The following is a description of a gene set: Genes in the cancer module 459. Human Gene Set: MODULE_459 species: Homo sapiens, and this is the list of marker genes: LEPROTL1, TMEM62, NOL7, CCAR2, FBXO11, MMP7, CDH5 (NCBI Gene Id 1003), RNF103, SENP1, PDCD6, BAIAP3, AMZ2, MPRIP, SLC11A2, TMED3, ACSM5, SCARA3, MAPK4, ZNF143, KATNAL1 (NCBI Gene Id 84056), KLHL41, EPHB6, RNASE6, TMEM144, CDK11A, SLC22A3, RPAP3, CD163, MST1R, INO80B, CD1A, PCGF1, NADSYN1, CORIN, RRAGD, TIMP4, SEMA4A, REV3L, SV2B, GEMIN7, TMEM161A, TMEM120A, CST1, GOLGA4, BTN2A1 (NCBI Gene Id 11120), COL6A3, HNRNPDL, BRAP, CHD1, SIAH1, EEF1D, SLC25A27, PARS2, CCNL1, PHAX, PLEKHM2, MMP9, PRPF39, KLHL4, SNRNP25, GRAPL-AS1, LRP3, PIP4K2C, LMTK3, NCF2, RNF220, ACVR1, PLGLB2, WRNIP1, LY9, STRN, CDH4, NECAP2, SUGP2, GPATCH3, ALKBH4 (alkB homolog 4, lysine demethylase), PHIP, SURF6, PAPOLA, EPB41L4B, ZMYM5, GEM, UGCG, GSN, GPR68, ATG16L1, OR2A1, MAGED4B, ACKR1, BEGAIN, TIMELESS, RBM7, AHNAK, NCOA7, NUP58, XPO4, FN1, ZGRF1, GJA1, ITGB5, CITED2 (NCBI Gene Id 154106), CAND1, EPHA7, TLN1, SPMAP2, ITM2C, PPP4R2, BCL2L14, CYP2A7, SLC19A1, OBSCN, ITGA4, CD8A, CHST9, NOP53, ELAC1, DDX60, CEP162, HMGN5, COCH, CYP1A1, MED12L, MRPL47, CXCL10, CCDC90B, MOB4, CTSZ, PAWR, ZBTB5, TMEM255A, NUP54, NACAD, ARHGAP20, ZNF117, IPCEF1, SLMAP, IL1RL1, MFSD1, SNX5, MAP2K6, CCDC81, KLHL36, MRPL27, WDR19, CELF2, ESPN, CXCL8, EIF2B4, TOR4A, DZIP3 (NCBI Gene Id 9666), MORC3, KATNIP, MREG, C1orf116, SFRP1, MICALL1 (MICAL like 1), SLC43A1 (NCBI Gene Id 8501), ACTR6, FMN1 (NCBI Gene Id 649014), POLDIP3, CACNA2D3, SMG7 (NCBI Gene Id 9887), MRPL36, BAG3, KAT2B, CCBE1, NELFB, HS1BP3, PCED1B, ZNF318, GJC2, DEXI, EYA3, OXGR1, TUBA4A, CCL2, TRIM48, FGFR1, TMCC2, FAIM, BCR, INIP, ART3 (NCBI Gene Id 419), APTX, NELFCD (NCBI Gene Id 51497), BFSP2-AS1, LARP1, ARG1, RPRM, WDR46, ILRUN, FGD6, TMEM47, MAL2, CSF2RB, RNF213, PDE4D, FBXW4, PAQR5, PIF1, DIO3, LYZ, PORCN, LANCL2, OTOR, PYGB, TNFRSF13C, DCTN3, PI4K2B, CEBPZ (CCAAT enhancer binding protein zeta), ARID5A, GPSM3, NME1, USP36, ZDHHC2, CDH22, PTGS2, LINC00160, IL1A, LACTB, LRRC14, ATG2A, FPR2, QSER1, CHD9, PLEKHG1, TFPI2, XRN2, ITK, ABI3, FUCA1, AASS, KCNE4, PGLYRP2, ZNF107 (NCBI Gene Id 7660), SDC3, GLB1L, TESPA1, KDM5B, TMEM250, TBC1D9, ALG6, SARAF, QKI, YWHAB, C19orf73, ANKRD13A, ABHD17C, ELOB, VIT, VNN1, REPIN1, CCDC134, MED28, CHL1, PTPRT, FABP2, ADIPOR2, DNAJA1P5, CBLN1, COPE, DNAAF4, ERLIN2, UFSP2, IL1R2, ATP8A2, DYNC2LI1, ATRN, ZNF264, HBE1, PPP1R14D, SAV1, POU6F2, CUL9, NSUN3, RNASEL, CCL11, AURKAIP1, MYL12A, NANS, ITGB1, OSBPL9, LRRC4C, TRABD, CELP, EPS15L1, CD1D, SLAMF7, LYL1, MRPL18, FLJ13224, OR7E12P, UTP11, PYCR3, MRPS15, SQOR, ITGAM, ATXN7, ACSL1, ERVMER34-1, ISYNA1, PITPNC1, SLC17A8 (NCBI Gene Id 64944), STAMBPL1, ANXA1, FAM220A (NCBI Gene Id 84792), BASP1, NUTM2F, BPIFA1, AMIGO1 (NCBI Gene Id 57463), ANKFY1, EARS2, TAL1, GPR26, DPYD, BRIP1, STAT3, UNC79, EREG, TDP1, MMP14, SLC26A8, NXPH4, TMT1A, TRIM14, COQ8A, CLCF1, CMTM6, MAPKBP1, KRT19, TRIM7, PRDM1 (PR/SET domain 1), MOCOS, ZNF566, LDAH, NGF, WDR25, SP140L, DCANP1, IL18R1, ARHGAP15, DES, PTPRZ1, HIF1A, CNOT6L, SSBP4, MED25, BGN, BSDC1, LNPK, DCLK1, CIP2A, PLEKHF2, TMLHE, ZKSCAN7, MICB, FNBP4 (NCBI Gene Id 23360), MBD5, FAM169A, SPSB4, AKAP8L, NEPRO, BCL2L13, CYYR1, SOX6, MXRA8, DCAF15, KDM4D, NRL, DLC1, LY86, ATG4D, S100A5, ZMAT4, GJA5, DNAH11, SPNS1, ASXL2, HOMER2, SIPA1L3, SMAD3, FURIN, HIVEP2, ZFP41, TMEM248, TBC1D8B, FOS, NR2E1, PKIA, DIRAS2, LRRN3, CHST1, HACD1, LAP3, TP53, POGLUT2, ARHGAP45, FAF1, AMY2B, ACE, PNMA8A, ELOVL2 (NCBI Gene Id 54898), RERE, STRIP2 (NCBI Gene Id 57464), GABPB1-IT1, TSLP, SH2B3, PRDM8, CCDC85C (coiled-coil domain containing 85C), CLUH, NEIL1, KIAA2013, EFCC1, ZCCHC4, TMEM121B, CDK16, SCD, MLYCD, MCTS1, EPCIP, ERMN, GOLGA5, TTF2, SLITRK1, CSF1, MTMR12, PDCD2L, LRRC19, TMEM97, NFIL3, C17orf75, MCMBP